Given this list of marker genes VPS13D, VCL, BTD, FAM131A, MLEC, ITGB1BP1, PECAM1, MKRN1, EEF1D, TFCP2, ANGPTL2 (NCBI Gene Id 23452), INPP1, LPCAT4, LSM4, CLEC10A, SETD2, RDH11, SLC39A7, MAF, RNF4, ZNF37A, LUM, ZNF212, ADAM12, PRPS1, KDELR1, SIX1, MAN2C1, FOLR2, DHX8, ABCC3, SLC16A7 (NCBI Gene Id 9194), RUSC1, PSIP1, PRIM2, KATNA1, P2RY14, RPL13P5, SRR, CX3CL1, IDH2, ILVBL, DUSP7, SPTSSA, LIPT1, MED22, GNGT1, TARBP2, RRN3, EPHA7, ARHGDIB, REEP5 (receptor accessory protein 5), MMP11, LPL, PTPN6, MTHFD1, NOTCH4, MYBPC3, CEP162, KAT2A, KSR1, ATP5MC3, TMEM106C, SEPTIN8, BAZ2B (bromodomain adjacent to zinc finger domain 2B), RHOBTB1, SLC22A5, TUSC2, FPGS, NUP160, R3HDM1, CCNI (NCBI Gene Id 10983), DIP2C, IKBKB, AKAP1, ARRB2, FASN, HCG4, IFITM2, KDM3B, NCOA6, MARS1 (NCBI Gene Id 4141), RBL1, ELF2, TRA2B, PLOD3, PKD1, NBR1, NRG1 (NCBI Gene Id 653104), PISD, SNRPF, NECAB3, SYN2, CCT3, MYL6B, CHEK2, EMG1, PMVK, CNOT4, CLDN10, XPO7, WDR43, ARHGEF4, JADE2, POLA1, YTHDC2, GCNT2, PIAS4, TMCC2, ADAMTS3, TLR3 (toll like receptor 3), SMARCD3, MOAP1, GPRC5B, FXN, SSX3, HADHB, IFNGR1, CNPY3, MYH15, NRP1, PPP1R12B, SNRNP35, ABCB1, ZNHIT1 (NCBI Gene Id 10467), N4BP2L2-IT2, PLCG2 (NCBI Gene Id 5336), CTSF, DOK2, RBMY2DP (NCBI Gene Id 650805), CD79B, H2AZ1, WDR1, PATJ, MPV17, LRPPRC, HMGA1, PNP, MIR22HG, DXO, TLX1, ZNF428, PPBP, IGLV1-44, TMED9, SCN5A, APLNR, CNOT1, B4GALNT1, RAB40AL, FAM53B, CRELD1, IL5, BTK, EIF4E2, VAV1, PGM5, FCGR3B, PRDM1, PEX2, DGCR2, POU1F1, ARTN, PTK2, SLCO2B1, ALG3, DNAJC11, NUCB2, FRY, CDON, TNFSF10, GATA2, AHNAK, ZNF787, QPRT, NUP133, DLEC1, SLC16A2, STIP1 (NCBI Gene Id 10963), ARL2, GRB7, CFDP1, IRAG2, ZBTB20, CACNB2, GRPEL1, KANK3, CKS1B, AOX1, NOLC1, PCBD1, NDUFB6, IDH3G, STIM1, PTPRA (protein tyrosine phosphatase receptor type A), OGDH, KRT14, PPM1F, PDZK1IP1, MDH1, here is a description of the gene set: from publication Chaussabel D, Semnani RT, McDowell MA, Sacks D, Sher A, Nutman TB (PMID 12663451) Human Gene Set: GSE360_L_MAJOR_VS_B_MALAYI_LOW_DOSE_DC_DN Genes down-regulated in comparison of dendritic cells (DC) exposed to L. major versus DCs exposed to 5 worms/well B. malayi. Monocyte-derived dendritic cells (DC) and macrophages (MΦ) generated in vitro from the same individual blood donors were exposed to five different pathogens, and gene expression profiles were assessed by microarray analysis. Responses to Mycobacterium tuberculosis and to phylogenetically distinct protozoan (Leishmania major, L. donovani, Toxoplasma gondii) and helminth (Brugia malayi) parasites were examined, each of which produces chronic infections in humans yet vary considerably in the nature of the immune responses they trigger. species: Homo sapiens